Given this list of marker genes Pcsk9, Acacb, Erlec1, Vps35, Insig1, Derl2, Nfkbia, Pkia, Ube2g2, Snx12, Os9, Svip, Fermt1, Nup153, Bard1, Sar1a, Rbm10, Rangap1, Ufm1, Cd36, Park7, Cryab, Fam76b, Pln, Abca2, Snx3, Nf1, Ubac2, Ei24 (etoposide induced 2.4 mRNA), Mapt, Ube2j1, Gbp4, Yod1 (NCBI Gene Id 76190), Hrc, Hnf4a, Cryaa, Apod, Tpr, Cabp1, Mdfic, Chp1, Mrln, Angpt1, Ywhab (tyrosine 3-monooxygenase/tryptophan 5-monooxygenase activation protein, beta polypeptide), Hdac3, Sp100, Sumo1, Arhgap8, Cnih2, Map1b, Sirt6, Arfip1, Pkig, Mtmr4, Ddx39a, Txn1, Rab23, Akap1, Cdk5, Derl3, Adipoq, Arhgap1, here is a description of the gene set: studied in species Mus musculus Mouse Gene Set: GOBP_NEGATIVE_REGULATION_OF_INTRACELLULAR_TRANSPORT Any process that stops, prevents, or reduces the frequency, rate or extent of the directed movement of substances within cells.